The following is a description of a gene set: Genes predicted to be targets of miRBase v22 microRNA mmu_miR_3620_5p in miRDB v6.0 with MirTarget v4 prediction scores > 80 (high confidence targets). studied in species Mus musculus from publication Chen Y, Wang X (PMID 31504780) Mouse Gene Set: MIR_3620_5P, and this is the list of marker genes: A830018L16Rik, Kcnj13, Slc25a13, Icosl, Prss22, Rad51b, Wbp1l, Bnc1, Jade1, Runx1t1, Pcmt1, Nfatc3, Eif3j2, Bmp8a, Tnrc6a, Kdm4a, Zfp963, Dsg1c, Eif3j1, Ccdc167, Fam53b, Myof, Dbx2, Plekhg1, Vwf, Ankrd54, Grm1, Asb7, Pms2, Wiz, Arrb1, Ap3s1, Wdr46, Borcs8, Gsta4, Il4i1, Slc30a7, Tmem175, Trpm1, Prlr, Coq4 (NCBI Gene Id 51846), Notch4